Given this list of marker genes Pgf, Adra1d, Ddah1, Nr3c2, Tbxa2r, Atp1a1, Edn3 (endothelin 3), Arhgap42, Ramp2, Scnn1g, Agtr2, Ffar3, Camk2n1, Ptgs2, Npy, Ednrb, Cartpt, Tnni3, Rarres2, Ace3, Nppa, Ece1, Ednra, Smtn, Nos2, Comt, Ntsr1, Spx, Cpa3, Cyp11b2 (NCBI Gene Id 13072), Adra1a, Drd5, Rps6ka2, Agtrap, Rhoa, Klk1b26, Agt, G6pdx, Ptpro, Bdkrb1, Pik3r1, Pomc, Oprl1, Crhr2, Anpep, Nox1, P2rx1, Pmch, Ephx2, Kcnj8, Uts2r, Tac4, Plcb3, Ptgs1, Or51e2, Acvrl1, Adamts16, Cacna1c, Drd3, Nr2f2, Tnf, Agtr1b, Cnr1, Nos1, Mas1, Adrb1, Ier3, Gna12, Nmu, Klk1b8, Chrm3, Avpr1b, Fshr, Calca, Sucnr1, Eng, Nkx2-1, Adra2b, Tac1, Hrh3 (NCBI Gene Id 99296), Ptafr, Slc4a5, Col1a2, P2rx2, Nav2, Edn1, Atp2b1, Atp6ap2, Lnpep, Ren1, F2r, Uts2b (NCBI Gene Id 224065), Npr1, Tpm1, Tac2, Gsk3a, Adm, Id2, Pdgfb, Kcnk3, Ncald, Adrb2, Glp1r, Qrfp, Adipoq, Prep, Drd2, Klk1b24, Serpinf2, Nos3, Mecp2, Adrb3, Slc2a5, Mrgprd, Npff, Ptpn1, Oxt, Ucn, Atp5pf, Aoc3, Snx5, Adm2, Dll1, Nampt, Grip2, Crh, Myh6, Rasl10b, Avpr2, Trpv1, Npy1r, Sod1, Klk1b22, Gpr37l1, Bmpr2, Gnas, Hsd11b2, Klk1b5 (NCBI Gene Id 16622), Klk1b1, Scpep1, Kdr, Gja5, Kl, Emp2, Bdkrb2, Stk39, Klk1b9, C3ar1, Ace2 (angiotensin converting enzyme 2), Enpep, Coro2b, F2rl1, Klk1 (NCBI Gene Id 68329), Ppara, Ext2, Kcnn4, Mc3r, Prcp, Npr3, Cyba (cytochrome b-245, alpha polypeptide), Postn, Klk1b21, Ar, Avpr1a, Tacr3, Corin, P2rx4, Kcnk6, Klk1b27, Chrna7, F11r, Lep, Mme, Gnaq, Hmox1, Gna13, Klk1b16, Abcc9, Avp, Smad3, Gucy1a1, Apln, Klk1b3, Agtr1a, Edn2, Abat, Asic2, Uts2, Ttr, Cacna1b, Tacr1, Ndst2, Acta2, Umod, Wnk1, Lrp5, Scnn1b, Vegfc, Guca2b, Ext1, Mkks, Gas6, Adra1b, Gna11, Nisch, Ace, Cyp2j5, Rnpep, Bbs4, Emilin2, Adh5, Klk1b4, Klk1b11, Mir1954, Arhgef12, Adora1, Manf, Atp1a2, Gch1, Apela, Ncf2, Nedd4l, Pparg, Mcpt4, Rnls, Kcnq1, Sod2, Ahr, Oxtr, Emilin1, Scnn1a, Gja1, Nppb, Wnk4, here is a description of the gene set: Any process that modulates the force with which blood travels through the circulatory system. The process is controlled by a balance of processes that increase pressure and decrease pressure. Mouse Gene Set: GOBP_REGULATION_OF_BLOOD_PRESSURE studied in species Mus musculus